The following is a description of a gene set: Mouse Gene Set: GOMF_OXIDOREDUCTASE_ACTIVITY_ACTING_ON_CH_OR_CH2_GROUPS_QUINONE_OR_SIMILAR_COMPOUND_AS_ACCEPTOR species: Mus musculus Catalysis of an oxidation-reduction (redox) reaction in which a CH2 group acts as a hydrogen or electron donor and reduces a quinone or similar acceptor molecule., and this is the list of marker genes: Cyp2c29, Cyp3a13, Cyp1a2, Cyp2c50, Cyp2c65, Cyp2c38, Cyp2c39, Cyp2c37, Cyp2c66